The following is a description of a gene set: studied in species Homo sapiens Congenital diaphragmatic hernia The presence of a hernia of the diaphragm present at birth. Human Gene Set: HP_CONGENITAL_DIAPHRAGMATIC_HERNIA, and this is the list of marker genes: MYT1L, CHRNG, EFEMP2, B3GAT3, GPC4, SF3B4, RAD21, EFNB1, PIGN (NCBI Gene Id 23556), SH2B1, NDUFB11, GATA4, ADAT3, TRRAP, HCCS, MAFB (MAF bZIP transcription factor B), MAMLD1, CTBP1, ALG9, KCNA1 (NCBI Gene Id 729214), PIGG, HOXD13, LONP1 (lon peptidase 1, mitochondrial), MAF, RPS28, DACT1, GPC3, NELFA, LTBP4, LFNG, SEC31A, MCTP2, MID1, NR2F2, RARB, MN1, CPLX1, WNT4, BRD4, SLC2A10, WNT3, POGZ, GATA6, CHST3 (NCBI Gene Id 9469), COX7B, KIAA0586, FLNA, RLIM, SMC3, ABL1, DHCR7, TAF6, HDAC4, CD96, CHUK, LETM1, MAP3K7, HDAC8, ARID1B, DLL3, WT1, VANGL2, HES7, PBX1, WNT7B, PCNA, STRA6, MYRF, NIPBL, ANAPC7, NSD2, ZFPM2, MESP2, SMAD2, PORCN, NDUFAF5, KMT2D (lysine methyltransferase 2D), DIS3L2, KDM3B, STAG2, PPM1D, SMC1A, RPS26, SMARCB1, NUAK2, MTHFR, SIN3A, PLS3, RSPO2, KDM6A, GLI3, ALDH1A2, RIPPLY2, CDC42BPB, FBLN5, WLS, TRAIP, EFEMP1, LRP2, KIF7, AR